The following is a description of a gene set: from publication Chen Y, Wang X (PMID 31504780) studied in species Mus musculus Mouse Gene Set: MIR_5129_3P Genes predicted to be targets of miRBase v22 microRNA mmu_miR_5129_3p in miRDB v6.0 with MirTarget v4 prediction scores > 80 (high confidence targets)., and this is the list of marker genes: Plvap, Irf2, P2ry13, Usp3 (ubiquitin specific peptidase 3), Pja2, Taf4, Acox2, Corin, Yipf6, Dcaf5, Dydc1, Cdc14b, Hecw2, Clock, Tpcn1, Prelid1, Ptger4, Cdkn1b, Add3, Brd1, Mylip, Tnrc6b (NCBI Gene Id 72625), Pcdhb3, Cacnb4, Arsk, Rin2, B3gat3, Kcnj2, Myof, Luc7l3 (NCBI Gene Id 67684), Aqp4, Tbl1xr1, Lrp2 (low density lipoprotein receptor-related protein 2), Col4a1, Rnf223, Mthfsl, Tnpo1, Cpeb1, Mbnl2, Tex12, R3hdm2, Usp9x, Mthfs, Tjp1 (tight junction protein 1), Atxn7l1, Gdap2, Peak1, Trim33, Dpyd, Ccdc74a